Given this list of marker genes Gm6993 (predicted gene 6993), Ormdl2, Golga7b, Sptlc2, Zdhhc9, Sptssb, Ormdl3, Ormdl1, Sptlc1, Sptssa (serine palmitoyltransferase, small subunit A), Sptlc3, Golga7, here is a description of the gene set: Mouse Gene Set: GOCC_PALMITOYLTRANSFERASE_COMPLEX species: Mus musculus A protein complex with palmitoyltransferase activity.